Given this list of marker genes PRKAG2 (NCBI Gene Id 7981), MED31, DECR1, PIP4K2A, CYP4B1, ACAT2, HACD1, HSD17B7, PLAAT2, DHCR24, NCOA2, PGS1, PIK3R6, SC5D, CPNE6, MVD, SGPL1, GK, MCAT, PPT2, DHCR7, MTMR12, ARSK, DGAT2L6, LPCAT1, ACOT12, PIK3R4, GLB1L2 (NCBI Gene Id 89944), PTGDS, ABHD4, ARV1, MLYCD, NSDHL, CREBBP, ACLY, FUT2, PNPLA5, G0S2, ORMDL1, MTMR9, TRIB3, PLA2G2F, CYP11B1, SMPD3, GLB1L, CYP2C8, PCTP, ACER3, TNFAIP8L3, HEXA, SBF1, IDI1, MED29, MED15, PLD4, ALDH3B2, SREBF2, NCOR2, ACSS3, PI4KA, ARNT2, PIK3CG, HSD17B1, PON3, PCYT1B, PLAAT3, CYP3A4, PTGES3 (prostaglandin E synthase 3), ACOX3 (acyl-CoA oxidase 3, pristanoyl), FAM120B, SEC23A, FDX2, PLPP1, PLIN2, OSBPL6, OSBPL8, CD36, FDXR, GDPD5, FAAH, PIP5K1A, CYP2R1, GLB1, PTGES2, SLCO1B1, SPHK2, SQLE, KPNB1, PLA2G5, CBR4, ARSL, HEXB, ACAA2, AGPAT4, CBR1, VAPB, SUMO2, ENPP7, PLA2G4C, CCNC, SLC51A, OSBPL2, PTGS1, MED10, SPNS2, MIGA1, GPX1, MED1, PHOSPHO1, BDH1, PLD3, HMGCL, MED25, PIK3R3, SYNJ2, TBL1X, ST3GAL2 (NCBI Gene Id 729518), ACSF2, ACBD5, FA2H, AGK, PRKD2, PEX11A, ACOT4, CDK19, SLC27A3, ECI2, ST6GALNAC6, TECR, PLA2G2D, ASAH1, ELOVL4, SLC10A2, MED23, PRKD1, SGPP2, CERK, ACAA1, NPAS2, LGMN, ACBD7, ACADL, HSD17B14, ALOX5, SLCO1A2, ALDH3B1, TNFAIP8L1, ACOT7L, SUMF1, FABP5, GAL3ST1, MTM1, FDPS, PLEKHA4, ACHE, NEU1, MTMR4, CPNE1, ETNK2, B3GALT4, CDS1, MECR, PNPLA7 (patatin like phospholipase domain containing 7), PLEKHA8, ELOVL2, ME1, TPTE, SLC44A2, ARSH, PMVK, CYP24A1, CYP4A11, ACER2, CSNK2A1, CERS5, NFYB, MED18 (mediator complex subunit 18), SPTLC1, ACSF3, PLPP3, CSNK2B, ALOX12B (NCBI Gene Id 242), LRP2, ELOVL3, DPEP2, ACOT8, HSD17B2, CYP1A2, SGMS1, GBA2, TNFRSF21, CSNK2A2, PRKAB2, SREBF1, POMC, MIGA2, HSD17B12, PTDSS1, THEM5, HACL1, APOA5, DEGS2, ACOT2, NEU2, ORMDL3, GPAT4, FUT1, ANKRD1, STS, PLA2G4B, INPP5F, PCYT2, MED27, MBTPS2, PCYT1A, HSD17B8, AGT, LPCAT4, PON2, MED21, NCOA6, TGS1, NCOA1, MED8, MBOAT7, PLPP6, DGAT2, HILPDA, PTDSS2, SCD5, GDPD1, TPTE2, PLA2G4D, PLA2G2A, TNFAIP8L2, NEU3, OSBP, GLB1L3, APOA2, SMARCD3, CHKB, A4GALT, ST3GAL3 (ST3 beta-galactoside alpha-2,3-sialyltransferase 3), CYP8B1, PTGS2, CUBN, ARF1, ELOVL1, MED24, ALOX15B, MTMR7, THRSP (NCBI Gene Id 82916), CYP21A2 (cytochrome P450 family 21 subfamily A member 2), CERT1, HSD3B2, CYP11B2, ACSBG2, M6PR, PITPNM3, HADHA, B4GALT5, STARD10, PPARD, TM7SF2, HMGCS1, CRLS1, UBE2I, SEC24D (NCBI Gene Id 9871), VAPA, ACOXL, AGPAT3, AWAT1, LBR, DBI, MORC2, ABHD5, ACAD11, NUDT7, ABCC3, MED16, HSD3B1, LCLAT1, PNPLA3, MED28, NR1H2, CRAT, PISD, NEU4, MED9, HSD17B4, TXNRD1, PIP4P1, ACOT13, CERS1, SULT2A1, GPAT2, PIK3C2G, CYP2C9, SIN3A, AGPAT5, SPTSSB, OCRL, PIK3CA, ACADVL (NCBI Gene Id 37), INPP5D, MED19, SLC44A5, PGP, PNPLA2, ABCB11, TIAM2, OSBPL10, PEMT, THEM4, MED17, HMGCR, MED30, PRKD3, CYP27A1 (cytochrome P450 family 27 subfamily A member 1), VAC14, SLC25A17, PPT1, SLC27A5, CIDEA, STARD3NL, AKR1B15, CYP4F8, LHB (luteinizing hormone subunit beta), MMAA, GPX2, B3GNT5 (NCBI Gene Id 84002), FIG4, BMAL1, ACOT7, SLC25A20, DEGS1, FABP6, GGT1, LTC4S, ECHS1, GALC, ACSL3, PITPNM1, SRD5A1, PITPNM2, TSPO, SLC44A3, ALDH3A2, MID1IP1, SELENOI, UGT8, PIK3R5 (NCBI Gene Id 23533), ACACA, ALB, PLIN3, GPD1L, MOGAT1, BMX, INPP5E, PLA2G2E, NR1H3, FABP9, HSD11B1, BDH2, PIK3R1, SMPD4, CYP19A1, CAV1, CARM1, SLC27A2, STARD6, HMGCLL1, OSBPL7, INPP5K, ALOX15, FADS2, ACP6, LPIN3, PRKACA, MTF1 (NCBI Gene Id 4520), ORMDL2, ARSG, FDX1, NR1H4, AGPS, HADH, GGPS1, HACD3, PRXL2B, PPARA, ST8SIA5, CYP4F2, CDS2, HACD2, HPGDS, SPTSSA, GSTM4, AKR1B1, MBTPS1, DPEP1, LPCAT2, ST6GALNAC5, GPD1, CYP2C19, SERPINA6, GPAT3, PIK3CD, PIKFYVE, OLAH, EHHADH, AKR1C2, MBOAT1, CPNE3, ABCC1, ACSL5, GPAM, MED20, MVK (NCBI Gene Id 4598), ACADS, MED13L, PLA2G4F, INSIG2, CDIPT, MCEE, AACS, CYP7B1, ACSBG1, MTMR10, PPM1L, ACOX1, CYP11A1, PLA2G3, SP1, PLEKHA2, GDPD3, PTGES, LPIN1, TMEM86B (NCBI Gene Id 255043), ARSD, FAR1, MTMR1, CLOCK, CYP1B1, MED4, TBXAS1, ARSJ, ACSM6, PTEN, INPP4B, INPP5J, PLEKHA3, PNPLA6, PI4K2B, RUFY1, APOA1, GK3, ARNT, PI4KB, SLC51B, PSAP, NFYC, ENPP6, GDE1, ALOX5AP, LIPI, PTPN13, AKR1C3, CYP7A1, MMUT, PLPP2, PNPLA8, PIP5K1B, MED22, MTMR14, SIN3B, STARD7, CDK8 (cyclin dependent kinase 8), PPARGC1A, HELZ2 (helicase with zinc finger 2), CYP46A1, CYP39A1 (NCBI Gene Id 51302), PIP4K2B, UGT1A9, HACD4, GPD2, MED11, GBA1, DECR2, SPTLC2, CYP17A1, AKR1C4, PRKACG, ETNPPL, PLD6, SLC44A1, MED12, CPNE7 (NCBI Gene Id 27132), ACSL1, MTMR2, CERS6, CPT2, SLC27A1, ACSL6, CYP4F11, SRD5A3, HAO2, SACM1L, PCCB, SEC24C (NCBI Gene Id 9632), MFSD2A, PPP1CB, GRHL1 (NCBI Gene Id 29841), FITM2, HSD17B3, ACADM, PLEKHA5, PIK3C2A, PLAAT5, RAB4A, NCOR1, CHD9, ARSA, HSD11B2, INPP4A, PRKAA2, LIPE, HPGD, CYP1A1, STARD4 (StAR related lipid transfer domain containing 4), GNPAT, FABP7, SLCO1B3, AHR, AGMO, HSD17B13, PIP4K2C, NRF1, ETNK1, MGLL (monoglyceride lipase), RAN, SCAP, ACBD4, NUDT19, ST3GAL5, FADS1, OSBPL3, SCD, OSBPL9, HSD17B11, ACOT9, SPHK1, SYNJ1, VDR, FDFT1, RXRB, MBOAT2, FHL2, PIK3CB, PPARGC1B, PLA2G6, MED26, HSD3B7, PTGR1, PIAS4, SLC10A1, ACAT1, CYP51A1, CTSA, RAB14, SCP2, PLA1A, FABP1, CPT1B, CHKA, PLA2G15, PPP1CC, CIDEC (cell death inducing DFFA like effector c), SAR1B, THRAP3, GPCPD1, SUMF2, ACSM3, CERS2, TSPOAP1, LPIN2, FASN, PNPLA4, SLC22A5, ELOVL7, OSBPL1A, ELOVL6, CEPT1, TBL1XR1, SRD5A2, MTMR3, PLAAT4, RXRA, SBF2, PON1, CYP4F3, CYB5B, MFSD2B, PTPMT1, ABCG2, FAR2, PLAAT1 (phospholipase A and acyltransferase 1), PLIN1, ELOVL5, MOGAT2, HADHB, HDAC3, GC, MSMO1, ABCB4, LDLRAP1, CYP27B1, AGPAT2, BCHE, EPHX2, PLA2G4E, CERS3, RGL1, CH25H, GLA, PLEKHA1, MED14, MOGAT3, MTMR8, PTGIS, TECRL, LPCAT3, ACACB, PIK3C3, HTD2, FABP4, PCCA, AMACR, CHPT1, OXCT2, CYP2D6, BAAT, PHYH, PLD1, PPP1CA, CYP4A22, SAMD8, MAPKAPK2, PLB1, DHRS7B, CYP4F22 (NCBI Gene Id 50992), PLBD1, INSIG1, PIK3C2B, SGPP1, PLEKHA6 (pleckstrin homology domain containing A6), ESRRA, HMGCS2, SMPD1, GLIPR1, PI4K2A, EP300 (NCBI Gene Id 2033), AKR1D1, PRKACB, ECI1, PLA2G4A, NDUFAB1, CYP2J2, OSBPL5, ACER1, FAAH2, SGMS2, CROT, B3GALNT1, MED13 (mediator complex subunit 13), TNFAIP8, NR1D1, STAR, ABCD1, ACOT11, AWAT2, ACOX2 (NCBI Gene Id 8309), MED6, ABCA1, CERS4, NFYA, SPTLC3, ARSI, AHRR, ALAS1, FABP3, ARF3, FITM1, ACOT1, GGT5, CGA, CPT1A, ARSF, GPX4, RORA, GM2A, PPARG, GK2 (glycerol kinase 2), LIPH, ASAH2, EBP, FABP2, GPS2, ABHD3, PITPNB, TAFAZZIN, B4GALNT1, AKR1C1, SLC44A4, PIP5K1C, CSNK1G2, ALOX12, SEC24A, CYP2U1, UGCG, ACSL4, LTA4H, MTMR6, ALPI, ARSB, NCOA3, GBA3, STARD5, ALOXE3, PTGR2, DDHD2, PLA2G12A, LSS, CHAT, ANGPTL4, PLA2G10, OXCT1, FABP12, RAB5A, PLA2G1B, LPGAT1, CYP2E1, KDSR, DDHD1, MED7, ACBD6, PLD2, B4GALT6, SEC24B, PLA2R1, AGPAT1, PECR, DGAT1, SMPD2, IDI2, ACAD10, PIK3R2, STARD3, INPPL1, here is a description of the gene set: Lipids are hydrophobic but otherwise chemically diverse molecules that play a wide variety of roles in human biology. They include ketone bodies, fatty acids, triacylglycerols, phospholipids and sphingolipids, eicosanoids, cholesterol, bile salts, steroid hormones, and fat-soluble vitamins. They function as a major source of energy (fatty acids, triacylglycerols, and ketone bodies), are major constituents of cell membranes (cholesterol and phospholipids), play a major role in their own digestion and uptake (bile salts), and participate in numerous signaling and regulatory processes (steroid hormones, eicosanoids, phosphatidylinositols, and sphingolipids) (Vance & Vance 2008 - URL).<p>The central steroid in human biology is cholesterol, obtained from animal fats consumed in the diet or synthesized de novo from acetyl-coenzyme A. (Vegetable fats contain various sterols but no cholesterol.) Cholesterol is an essential constituent of lipid bilayer membranes and is the starting point for the biosyntheses of bile acids and salts, steroid hormones, and vitamin D. Bile acids and salts are mostly synthesized in the liver. They are released into the intestine and function as detergents to solubilize dietary fats. Steroid hormones are mostly synthesized in the adrenal gland and gonads. They regulate energy metabolism and stress responses (glucocorticoids), salt balance (mineralocorticoids), and sexual development and function (androgens and estrogens). At the same time, chronically elevated cholesterol levels in the body are associated with the formation of atherosclerotic lesions and hence increased risk of heart attacks and strokes. studied in species Homo sapiens Reactome Pathway: Metabolism of lipids part of: Metabolism